The following is a description of a gene set: Human Gene Set: GOBP_NEGATIVE_REGULATION_OF_CIRCADIAN_RHYTHM species: Homo sapiens Any process that stops, prevents, or reduces the frequency, rate or extent of a circadian rhythm behavior., and this is the list of marker genes: PIWIL2, CRY2, CRH, DRD2, SIN3A, PASD1, CIPC, ADORA1, PER2, GHRL, SFPQ, CRY1